The following is a description of a gene set: Co-inhibition by CTLA4 Human Gene Set: REACTOME_CO_INHIBITION_BY_CTLA4 studied in species Homo sapiens, and this is the list of marker genes: SRC, PPP2R5A, AKT3, FYN, LYN, LCK, AKT1, PPP2R1A, PPP2R5B, YES1, PPP2R5D (protein phosphatase 2 regulatory subunit B'delta), PPP2R5C, CTLA4, PPP2CB, CD80, CD86, PPP2CA, PPP2R1B, PPP2R5E, PTPN11, AKT2